Given this list of marker genes HSPA8, APOE, FKRP, SNX33, ARHGEF5 (Rho guanine nucleotide exchange factor 5), CLU, APP, LAMP2, B4GALNT2, GPIHBP1, PRF1, here is a description of the gene set: Human Gene Set: GOBP_PROTEIN_IMPORT species: Homo sapiens The targeting and directed movement of proteins into a cell or organelle. Not all import involves an initial targeting event.